The following is a description of a gene set: Mouse Gene Set: MIR_6375 from publication Chen Y, Wang X (PMID 31504780) Genes predicted to be targets of miRBase v22 microRNA mmu_miR_6375 in miRDB v6.0 with MirTarget v4 prediction scores > 80 (high confidence targets). species: Mus musculus, and this is the list of marker genes: Hnrnpdl, Kif2a, Usp24, Scyl3, Slc35f1, Atp6v1a, Mrpl9, Plscr3, Ctla2b, Tmed2, Kcnv1, Ppp1r13b, Zbtb43, Sowahb, Rapgef2, Prune2, Gucy1b1, Npdc1, Il21r, Ntng1, Lcor, Gsta4 (NCBI Gene Id 14860), Ssx2ip, Arf4, Saa4, Pcdh10, Tbl1xr1, Ttc28, Stard3, Rab27a, Znfx1, Fbxo33, Chn1, Efcab2, Foxo4, Mmd (NCBI Gene Id 69866, monocyte to macrophage differentiation-associated), Prkacb, Cfl2